The following is a description of a gene set: studied in species Homo sapiens Genes having at least one occurrence of the motif TTGGCGCGRAANNGNM in the regions spanning 4 kb centered on their transcription starting sites. This matches the E2F1 transcription factor binding site V$E2F1_Q3_01 (v7.4 TRANSFAC). Human Gene Set: E2F1_Q3_01, and this is the list of marker genes: ENHO, RAD23A, TPK1, E2F1, TCF15, INSM1, PPP1CA, S1PR2, KPNB1, INTS7, NAT8L, GRIN2A, TRPS1, VAX1, DLEU1, STAG2, FOXO3, TLK2, KLF13, STAG1, TMEM150A, AK2, SDHAF2, RANBP1, DUSP7, ZNF516-DT, PCLAF, ZCWPW1, TPI1P2 (NCBI Gene Id 392986), STMN1, ARRDC1-AS1, MEPCE, LYL1, NR2E1, FKBP2, EIF4G1, PSMD2, AHCTF1, EN1, ANKRD13A, ZMYM4, ID3, ELK3, HR, FGF11, TRMT2A, BMAL1, EIF5, RSF1 (remodeling and spacing factor 1), KCND3, KCNA1, FOSL2, FHIP1B, SLC12A5, CGGBP1, VAMP3, CPSF7, ABCB9, EIF1AY, EGR3, H2AC12, DNMT1, TMEM59L, PELI2, RELN, OGFOD2, MEIS1, PHF23, DDX50, TNPO3, NRGN, TMEM256, HNRNPD, SATB1, MARCKS, DCLK1, NTN1, ROR1, FAM219A (NCBI Gene Id 203259), NKX6-2, PRIM1, NR4A3, IDH3G, LGALS1, BRMS1L, SLC25A28, TTC17, JUNB, MEIS2, PUF60, ST3GAL5, GGA1, CLPTM1, CBARP, LNX2, CENPB, EIF5A, TOPBP1, OSBPL7 (oxysterol binding protein like 7), SLC35D1, PPP1CC (protein phosphatase 1 catalytic subunit gamma, NCBI Gene Id 5501), PTCHD1 (NCBI Gene Id 139411), SMARCA1, YWHAQ, MLLT6, AP4M1, MAP1A, ISL1, ZMYM2, TJAP1, KLF4, SPOCK2, ELAVL4, MAZ, TRPM7, RND2, GTF2A1, UBR5, TRIM39, KLF10, HAPSTR1, PCSK4 (proprotein convertase subtilisin/kexin type 4), CALM2, DNAJC11, CDKN1C, DUSP6, C6orf89, LCOR, CADM1, GSPT1, HMBS, USP2, ZNF565, YTHDC1, APOE, KY, RBL1, ANKRD13D, KCNB2, MCM7, MAML1, DCTPP1, SHROOM2, CDK6, MCMBP (minichromosome maintenance complex binding protein), DNAJC9, ELMO2, ZFAND2B, SIK1, UNC13B, SYNCRIP, RAB2A, IRF2BP1 (interferon regulatory factor 2 binding protein 1), C1orf43, DLEU2, UBALD2, LMX1B, AXIN2, PTPRU, XPR1, CPNE5, CALM1, TMEM187, CTDSP1, RECK, EDEM1, NRG2, IMPDH2, TLE3, FBXW4, FUT8, CYTH2, FXR2, POLA1, KLHL11, SRSF7 (NCBI Gene Id 87459), MYC, FBXO9, UHRF2, PLK4, RASD2, MRC2, PHF21A, PHF20, RMI2, WEE1, SENP3, ZNF318, ARHGEF19, ATXN1, RNF167, ZNF367, HOXA13, ABI2, NONO, ATAD2, ZBTB12, SYT6, ARX, DMD, ALDH6A1, ARHGEF12, NEUROD2, ITPKA, DHH, SATB2, SLC25A11 (solute carrier family 25 member 11), LHX2, PTGES3, CDC25A, H2BC12, NR2F2, PHF12 (PHD finger protein 12), ITGA3, FGF13, KCNH5, DCK, TMEM25, TPBG, POLR1D, HNRNPUL1, ZNF521, POMZP3, KRCC1, P2RY2, PRDM16, RPS6KA5, CDK9, LRP8 (NCBI Gene Id 7804), YTHDF2, AAMDC (adipogenesis associated Mth938 domain containing), GABPB2, CELF4, GNB2, SLITRK3, ZFP36L2, NCAM1, KMT2E, NECTIN1, FOSL1, ARPC5L, SSR4, HMGN2, HS6ST2 (NCBI Gene Id 90161), EZH2 (enhancer of zeste 2 polycomb repressive complex 2 subunit), BRAF, ADAM23, MSI1, GMNN, ERG